The following is a description of a gene set: Human Gene Set: REACTOME_DOPAMINE_CLEARANCE_FROM_THE_SYNAPTIC_CLEFT Dopamine clearance from the synaptic cleft studied in species Homo sapiens, and this is the list of marker genes: LRRC51, COMT, LRTOMT, SLC6A3, MAOA